The following is a description of a gene set: part of: Regulation of TP53 Activity This event has been computationally inferred from an event that has been demonstrated in another species.<p>The inference is based on the homology mapping from PANTHER. Briefly, reactions for which all involved PhysicalEntities (in input, output and catalyst) have a mapped orthologue/paralogue (for complexes at least 75% of components must have a mapping) are inferred to the other species. electronically inferred by orthology from the curated human pathway Reactome Pathway: Regulation of TP53 Activity through Acetylation studied in species Mus musculus, and this is the list of marker genes: Pip4k2c, Pip4p1, Mta2, Rbbp4, Brpf3, Ing2, Mbd3, Rbbp7, Ep300, Trp53, Brpf1, Map2k6 (mitogen-activated protein kinase kinase 6)